The following is a description of a gene set: Genes related to regulation of the actin cytoskeleton species: Homo sapiens Human Gene Set: SIG_REGULATION_OF_THE_ACTIN_CYTOSKELETON_BY_RHO_GTPASES, and this is the list of marker genes: CDC42, LIMK1, VASP, FSCN3, FLNC, ROCK1, ACTR3, FSCN1, MYH2, ROCK2, PAK5, PFN1, MYLK2, ACTG2, PAK6, FSCN2, PAK4, PAK2 (NCBI Gene Id 9106), WASL, ACTG1, WASF1, RHO, FLNA, ACTR2, GDI2, MYLK, AKT1, CFL2, PAK3, PFN2, RPS4X, GDI1, PAK1 (NCBI Gene Id 5058), CFL1, ANGPTL2 (NCBI Gene Id 23452)